The following is a description of a gene set: Genes up-regulated in dendritic cells with IFNAR1 knockout: CD8A versus ITGAM+. Human Gene Set: GSE45365_CD8A_DC_VS_CD11B_DC_IFNAR_KO_UP Murine Cytomegalovirus (MCMV) infection leads to early activation of various immune cells, including B and T lymphocytes, before the actual initiation of antigen-specific adaptive immunity. This activation is partly driven by innate cytokines, including type I interferon (IFN), which are induced early after infection. The objective of this study was to address the role of type I IFN in shaping early/innate B and T cell responses to a primary acute viral infection. In order to decipher the specific impact of IFN-I on cell subsets, we performed a genome-wide expression analysis on WT splenic B and CD8 T lymphocytes isolated from C57BL/6 mixed bone marrow chimera mice. This study complements series GSE39555, which focused on early responses of NK cells and of the two subsets of conventional dendritic cells. species: Homo sapiens, and this is the list of marker genes: GRID1, CRBN, P2RX5, EAF1, BRK1 (BRICK1 subunit of SCAR/WAVE actin nucleating complex), ZNF334, LPGAT1, KLHL29, OR12D3, C14orf39, LINC02035, SAT1, RAB39B, PLK2, SELENOK, TRAPPC5, PALLD, IER3IP1, CDKN1C, FRZB, SUZ12, MAGEA3, EIF1, RBM26-AS1, FASTKD3, ZNF844, ALCAM, SEM1, TOP6BL, POLR3F (RNA polymerase III subunit F), EPHB1, CEP15, SLC5A1, GNPAT, SNAP25, SLC4A7, NALCN (NCBI Gene Id 93074), RBM12, PLCD4, CCDC66, EVI5, USP9X, DUSP14, DUSP1, ABHD18, CEP41, LINC00665, KCNC1 (NCBI Gene Id 3746), ERCC4, NHS, IRS2, ZNF780B, VAMP7, ZNF682, PRTFDC1, SYTL5, NDFIP2, MEX3C, GTF2A1L, KLF11, SLPI, TMEM17 (transmembrane protein 17), SFRP1, PROP1, GJB2, PXDN, GPR180 (NCBI Gene Id 160897), CLDND1, ADNP, KCNK1, PAQR3, METTL6, GPNMB, POLD3, ZNF492, IFT20, CALM2, PLS3, CSTF1, SDE2, SOX9-AS1, IGF1R, RAB27B (RAB27B, member RAS oncogene family), SPATA17, NAA50, GPR85, SEC22C, MAGEH1, ZFAS1, PCNP, ZNF136, RAB25, ZNF468 (NCBI Gene Id 90333), RHCE, MGST1, PCDH8, LPAR3, OLIG2, SMARCE1, RUNX3, SMS, PRAMEF11, GET1, RBM46, PRDM16, ATP6V1A (ATPase H+ transporting V1 subunit A), ECT2, CHERP, CPS1, DUSP5, TDO2, ALDH1A1, FMR1, ANXA3, PCDH19, LINC00667, DUSP3, DZIP3, ADCK2, ZNF700, GLT8D1, TNMD, ZNF404, TRAPPC2, TFAP2C, ZXDC, LGR5, ZNF667-AS1, MATN1-AS1, RAB40C, LINC02871, ZSCAN21, PRRX1, PIGN, AMBN, ZNHIT3, GPM6A, SRSF11, HERC2P3, DR1, VPS50, XK, LPP, ETS1, ZNF677, REEP3, ERC1, RAP2A, RBBP7, PIGP, GNG11, CLDN1, LRRN1, CRISP2, IFT57, SLFN12, PPL, TMEM168, S1PR2, B3GNT5, NCBP2AS2, ACTL6A, DTNA, ZNF711, CXCL8, OLIG1, VGLL3, IL17RD, DUSP8, TMEM45A, NCBP2, WIF1, ARMCX3, LINC00205, TIMM21, PXYLP1 (NCBI Gene Id 92370), RAB9A, MMP9, ZNF440, GPR37, STS, TMEM185A, MAST4, SMC4, BEX1 (NCBI Gene Id 55859), TCEAL7, ZNF320, MKX, ATP11B, TSPAN31, SRD5A1, CHST9, AP1S2, PUDP